Given this list of marker genes Apoc2l, Apoc2, Apoh, Apoa5, Gpihbp1, here is a description of the gene set: Mouse Gene Set: GOMF_LIPOPROTEIN_LIPASE_ACTIVATOR_ACTIVITY Binds to and increases the activity of a lipoprotein lipase, an enzyme that catalyzes of the hydrolysis of a lipid within a lipoprotein. species: Mus musculus